Given this list of marker genes IGF1, PARP2, MIR208A, AKAP6, MIR19B1 (microRNA 19b-1), MIR19A, EDN1, MIR199A1 (NCBI Gene Id 406976), here is a description of the gene set: studied in species Homo sapiens Any process that increases the rate, frequency, or extent of the growth of a cardiac muscle cell, where growth contributes to the progression of the cell over time from its initial formation to its mature state. Human Gene Set: GOBP_POSITIVE_REGULATION_OF_CELL_GROWTH_INVOLVED_IN_CARDIAC_MUSCLE_CELL_DEVELOPMENT